Given this list of marker genes Cobl, Lpar1, Evi5l, Ift88, P2ry12, Fuz, Cep135, Ripor2, Mark4, Plxnb3, Syne1, Myo3b, Cdc42ep1, Dynlt2b, Dock11, Dnm3, Evl, Nckap1, Mien1, Sdccag8, Src, Cdc42, Odf2, Fnbp1l, Ccl21f, Hap1, Dmtn, Ift20, Ccl21b, Rala, Cttn, Ccl21a, Saxo1, Stau2, Cyfip1, Pik3r1, Bin3, Cdkl5, Cyld, Zmynd10, Tmem67, Hrg, Arhgap44, Sh3yl1, Aqp1, Pfn2, Avil, Gsk3b, Hras, Atp8b1, Akirin1, Septin9, Odf2l, Stap1, Rhoq, Cdc42ep3, Mphosph9, Mir129-2, Htt, Prl2c2, Plppr5, Ppp1r35, Hdac4, Plekhm1, Gm14137, Clrn1, Dnm2, Rab3ip, Ccdc88a, Auts2, Ccp110, Brk1, Mstn, Usp17le, Def8, Tbc1d30, Rabep2, Pfn1, Pld1, Ccr7, Tesk1, Plce1, Ccl21d, Wdpcp, Tchp, Limk2, Cav1, Abi3, Mns1, Gdi2, Mak, Tapt1, Podxl, Actr2, Ttbk2, Atg5, Pqbp1, Plek2, Cdc42ep4 (CDC42 effector protein 4), Zmynd8, Hsp90aa1, Trim32, Fam98a, Palm, Cdc42ep5, Wasl, Frmd7 (FERM domain containing 7), Entr1, Rap1gap, Arf6, Abi2, Arhgap35, Mcidas, Tgfb3, Rcc2, Dync2li1, Coro1c (coronin, actin binding protein 1C), Icam1, Fer, Cenpj, Tgfbr1, Agrn, Kank1, Eps8l1, Cep97, Eps8l3, Cfl1, Myo3a, Tbc1d7, Adamts16, Arap1, Hnf4a, Srf, Prkcd, Anln, Slit2, Dcdc2a, Atmin, Arhgap24, Wnt1, Carmil2, Ccl21e, Rac2, Dpysl3, Fmr1, Ccl19, Apc, Espn, Cln3, Klf5, Epha2, Rdx, Trpm2, Tacstd2, Rab11fip3 (RAB11 family interacting protein 3 (class II)), Cdc42ep2, Wasf2, Abitram, Rac1, Twf1, Akt1, Cdk10, Mtor, Actr3, Myo10, Arpc2 (NCBI Gene Id 76709), Arf4 (ADP-ribosylation factor 4), Crocc, Ndel1, F2rl1 (F2R like trypsin receptor 1), Kif24, Cep120, Daam2, Marchf7, Wrap73, Tenm2, Prkcq, Twf2, Bbs4, Rab17, Kit (NCBI Gene Id 16590), Nrxn1, Dynll1, Syne2, Ift140, Gap43, Noto, Ppp1r16b, Was, P2rx7, Gpm6a, Eps8l2, Rab11a, Lima1, Atp7a, Dbn1, Luzp1, Mapk15, Capzb, Tenm1, Ift46, Dzip1, Cntrob, Fscn1, Intu, Ppp1r9a, Kctd17, Rab5a, Neurl1a, Ephb2, Fam110c, Cdkl1, Rp1, Atg3, Eps8 (NCBI Gene Id 13860), Wdr44, Odad3, Nrp1 (neuropilin 1), Yap1, Nlgn1, Rhog, here is a description of the gene set: Any process that modulates the rate, frequency, or extent of cell projection assembly. species: Mus musculus Mouse Gene Set: GOBP_REGULATION_OF_CELL_PROJECTION_ASSEMBLY